The following is a description of a gene set: Mouse Gene Set: REACTOME_TNFR1_INDUCED_NF_KAPPA_B_SIGNALING_PATHWAY species: Mus musculus TNFR1-induced NF-kappa-B signaling pathway, and this is the list of marker genes: Rbck1, Tnfrsf1a, Optn, Traf1, Birc3 (NCBI Gene Id 11796, baculoviral IAP repeat-containing 3), Ikbkb, Tab3, Tab1, Uba52rt, Usp2 (NCBI Gene Id 53811), Otud1 (NCBI Gene Id 71198), Rack1, Ubc, Ubb, Spata2, Tnf, Tab2, Cyld, Tnfaip3, Rps27a, Ripk1, Birc2, Usp21, Tradd, Chuk, Traf2 (TNF receptor-associated factor 2), Map3k7, Uba52, Usp4, Ikbkg, Otud7b, Xiap, Rnf31